The following is a description of a gene set: species: Mus musculus Mouse Gene Set: GOCC_PHAGOLYSOSOME A membrane-bounded intracellular vesicle formed by maturation of an early phagosome following the ingestion of particulate material by phagocytosis; during maturation, phagosomes acquire markers of late endosomes and lysosomes., and this is the list of marker genes: Pfpl, Slc48a1, Adam8, Mpeg1, Lamp1, Pla2g5